Given this list of marker genes Sema6d, Myc, Cdkn2b, Socs5, Pglyrp3, Tert, Inpp4b, Lilrb4a, Lgals1, Flt3, Cbfb, Clec2g, Ednrb, Lyn, Ccl3, Pik3r1, Ceacam1, Mag, Vsx2, Btg2, Ccl11, Hook3, Ptk2, Daam2, Casz1, Wnt3a, Cartpt, Zbtb7b, Inpp5d, Tmem176a, Dab1, Runx1, Lhx2, Ifnb1, Lin28a, Atoh1, Gpr68, Pglyrp4, Hes5, Rb1, Nodal, Lingo1, Cdh1, Ctnna1, Trim46, Plxna3, Drd3, Qki, Nr1d1, Tob2, Tgfb1, Rest, Psen1, Shb, Efnb3, Mbp (NCBI Gene Id 98130), Sox10, Tlx2, F2, Pthlh, Igf1, Actr3, Kifap3, Gpr137b, Sema3a, Gdi1, Zbtb46, Ppp3ca, Rnf10, Cdkl3, Hes1, Pglyrp2, Prdx2, Prtg, Nf1, Tbx21, Pira1, Prdm16, Jak3, Mycn, Cldn18, Cfl1, Id1, Slc4a2, Dlx2, Ntrk3, Ptprs, Rgma (NCBI Gene Id 244058), Il1b, Rufy3, B2m, Fbxo7, Npr2, Ski, Draxin, Sfrp1, Dll3, Fgfr3, H2-M3, Sema5a, Kdm1a (NCBI Gene Id 99982), Foxj1, Zfp608, Bmyc, Pten, Tspo, Ulk2, Tbx6, Tcta, Vegfa, Ptpn2, Pcm1, Rtn4, Dtx1, Tnr, Il1a, Kctd11, Tmem176b, Kdm4a (lysine (K)-specific demethylase 4A), Rc3h2 (ring finger and CCCH-type zinc finger domains 2), Ptn, Nme2, Id4, Trib1, Cdk5, Sema4f, Wnt7b (wingless-type MMTV integration site family, member 7B), Nkx6-2, Sirt2, Cd74, Tsc2, Nme1, Sema3f, Rara, Syt4, Nog, Tmem178, Snai2, Gpr37l1, Cdkn2a (NCBI Gene Id 18560), Nfatc4, Wnt7a, Cd44, Anxa1, Gsk3b, Clec4g, Mt3, Bmpr1a, Clec2i, Bcl11a, Bmp7, Cd24a, Gpr55, Cysltr2, Tjp2, Loxl3, Pax6, Ntn1, Nfkbid, Zfpm1, Hspb1, Runx3, Gata2, Ctnnb1, Fgf13, Rflna, Sorl1, Tmem131l, Trim11, Slit1, Zc3h8, Cul4a, Ltf, Fbn1, Sema3g, Abcc8, Hlx, Socs1 (NCBI Gene Id 12703), Mafb, Tmem98, Vax1, C1qc, Hspa9, Lrrc17 (NCBI Gene Id 74609), Lilrb4b, Rflnb (refilin B), Hmga2, Irgm1, Rc3h1, Grb14, Appl2, Gli3, Mir133b, Bcl6, Sema6c, Lrp4, Wnt3, Tnfaip6, Iapp, Ttpa, Dnajb11, Apcs, Brinp1, Ifrd1, Frzb, Fbxw7, Il2 (NCBI Gene Id 16183), Rnf6 (NCBI Gene Id 74132), Trpc6, Bmp4, Cd69, Pf4, Cit, Trem2, Ctla4, Ulk1, Ephb2, Ifng, Bdnf, Ascl2, Il4ra, Tsc22d1, Atf5, Idh2, Trpv1, Pglyrp1, S1pr3, Dusp10, Mbd1, Ttc3, Nrarp, Spinkl, Slit2, Trak2, Foxp3, Pias3, Syngap1, Id2, Fstl3, Ctdsp1, Dicer1, Cav3, Tnfsf18, Nr2e1, Zfp35, Thy1, Notch1, Rapgef2, Ryk, Thoc5, Cftr, Ccr5, Adipoq, Hmgb3, Mdk, Trpc5, Gorasp1, Mecp2, Hdac6, Dlx1, Hoxa7, Prox1, Hmgb1, Pitx3, Dleu2, Ldlr, Nox1, Ywhah, Clec2d, Cebpa, Spart, Trp53, Sox11, Il4, Nkx6-1, Adcyap1, Arhgef2, Fstl4, Shh, Cers2, Ihh, Dynlt1b, Nppc, Rtn4r, Nf2, Pilrb1, Rag2 (recombination activating gene 2), Wee2, Cdk6, Epha7, Smad7, Tnfsf4, Clec12a, Fgl2, Dpysl5, Map2, Nrp1, Tnfrsf11b, Dip2b, Wnt5a, D130043K22Rik, Ubash3b, Lag3, Irf1, Mfn2, Il17d, Erbb2, Zc3h12a, Erfe, Gpr137, Fas, Arhgap4, Pira12, here is a description of the gene set: Any process that decreases the rate, frequency or extent of the progression of the cell over time, from its formation to the mature structure. Cell development does not include the steps involved in committing a cell to a specific fate. Mouse Gene Set: GOBP_NEGATIVE_REGULATION_OF_CELL_DEVELOPMENT species: Mus musculus